The following is a description of a gene set: Human Gene Set: HP_ABNORMALITY_OF_CENTRAL_NERVOUS_SYSTEM_ELECTROPHYSIOLOGY species: Homo sapiens Abnormality of central nervous system electrophysiology, and this is the list of marker genes: SCARB2, GJC2, ZNHIT3, PPFIBP1, IER3IP1, LAMC3, B3GALNT2, MT-TL1, WWOX, GRIN2D, NPRL3, HIC1, JRK, MAP2K2, PRNP, COL13A1, MADD, MTMR2, UGDH, TLR3, CLCN2, CHRNA4, C1QBP, SHQ1 (SHQ1, H/ACA ribonucleoprotein assembly factor), HNRNPU, ALDH7A1, AHDC1, NECAP1, FGFRL1, GLS, DOCK7, UCHL1, PURA, MAPK10, PACS2, ST3GAL5 (ST3 beta-galactoside alpha-2,3-sialyltransferase 5), MOGS, CPLX1, ATXN1, LRPPRC, ATP6V1A, PI4KA, FOXG1, PIGG, VAMP1, ZNF526, PDE2A, UPB1, KCNC1, CDKL5, TUBGCP2, CLCN4, PROM1, RUSC2, APC2, SCN1B, SLC5A7 (NCBI Gene Id 60482), GOSR2 (golgi SNAP receptor complex member 2), SLC25A10, DALRD3, HECW2, KCTD7, XPC, HMGCL, ADGRV1, NEU1, TPRKB (TP53RK binding protein), CUL3, KARS1, SLC35A2, ATXN10, IQSEC2, PHACTR1, MYO9A, KCNQ2 (potassium voltage-gated channel subfamily Q member 2), RERE, CUL4B, RELN, NTRK2, GABRG2, YRDC, MFSD8, SPTBN1, POMT1, MTHFR, ARSA, HRAS (NCBI Gene Id 338029), PRKCZ, PEX10, DOLK, DEPDC5, GABBR2, SATB1, AHSG, UBA5, ASPA, ACOX1, PEX6, CEP85L, NDRG1, ST3GAL3 (NCBI Gene Id 6487), SNIP1, FKRP, ARFGEF1, PIK3CA, MT-TH, TBC1D2B, NDUFAF8, TRPM3, ABCB7, TRIM8, FXN, EPG5, YWHAG (NCBI Gene Id 96443), D2HGDH, SMS, CTBP1, CLCN7, BRAF, POMGNT1, NALCN, ATP6V0A1, PRDM16, ATP1A3, ALS2 (NCBI Gene Id 65058), PCDH12, RTN2, ABCC8, DNM1, DIAPH3, ADGRG1, UBAP1, CNTNAP2, AARS1, NDP, NMNAT1, PDHA1, NEDD4L, GAD1, SLC6A1, GLUD1, NTNG2, ARHGEF2, CSTB, SLC1A4, SCN1A, PPT1 (palmitoyl-protein thioesterase 1), FOXP1, FLII, PTS, POLG, DOCK6, ADK, PRPS1, MT-ND5, NUS1, CLN8, HCN1, COQ4, GRIA3 (NCBI Gene Id 2892), ERCC4, CACNA2D1, CDK19, COMT, COG3, PEX3, PEX16, AIMP2, NUP107, AFG2A, NDUFA9, CABP4 (NCBI Gene Id 57010), HIKESHI, SLC18A3, PIGW, MARCHF6, SRPX2, CHI3L1 (chitinase 3 like 1), IARS2, TNFSF11, ABCD1, EMC1, TUBB2A, SH3TC2, SLC2A1, NLGN4X, MCOLN1, WDR62, ATP6V1B2, COX6B1, PLPBP, PRRT2, ALDH4A1, SYNJ1, NPRL2 (NPR2 like, GATOR1 complex subunit), NDUFS2, UBTF, SPG7, LARS2, SLC12A6, CNTN2, PRKAG2, DENND5A, DHPS, TBC1D24, CPT1C, ERCC1, RPL10, GABRB3, PLCH1, EP300, LONP1, STXBP1, MTHFS, AMT, PRODH, SETBP1, FDXR, DHDDS, AARS2, OCRL, SLC39A8, TRAPPC12, KPTN, TBK1, NSRP1, CLTCL1, PEX11B, RAB3GAP1, ERCC2, BRAT1, MFF, MFN2, ALDH5A1, ATAD1, NDUFS4, SPG11, MT-ND4, DPM2, GABRD, PCDH19, RNF13, LSS, PHGDH, ABCA4, GABRA1, AASS, ABAT, EDNRB, PLCB1, KMT2D, CHD2, MT-ND6, SMC1A, CTNNA2, MED23, CREBBP, TYR, PIGT, PIGO, OTOF (otoferlin), AP3B2, TRIT1 (NCBI Gene Id 54802), PIGV (phosphatidylinositol glycan anchor biosynthesis class V), DNM1L, VCP, DNAJC30, CERS1, CDK5, EOGT, NACC1, SOX10, GABRA5, APOL2, ADRA2B, NOTCH2NLC, TGFB1, LAMA2, SLC32A1, OTUD7A, CAMK2A, KANSL1, GALC, BCS1L, TYROBP, PIGP (NCBI Gene Id 53821), RAB3GAP2, CACNA1H, GLYCTK, SLC9A6 (NCBI Gene Id 53362), GABRA2, AFG3L2, SEMA6B, POMT2, IREB2, ERCC3, CNPY3, TICAM1, NOTCH3, OSTM1, PEX13, SLC44A1, CPA6, MED13L, GRIN2A, PHF6, NSF, TRAPPC11, NRAS, ANKRD17, CLTC, XPA, LMNB1, PSAP, PIDD1, CWC27, MT-TW, MYH3, ATN1, ITPR1, SCN8A, MT-ND1, MT-TS2, NTNG1, PDPN, SUOX, SLC13A5, NUP188, OCA2, GNAO1, YWHAE, MT-CO2, SLC6A19, CACNA1B, FGF13, PLP1, PNKP (polynucleotide kinase 3'-phosphatase), KCNA2, SYNGAP1, SCN2A, KCNT2, SUCLA2, SCN3A, SPTAN1, CELF2, PSAT1, GFM2, MYD88, VAMP2, CLTRN, PEX12, STRADA, PI4K2A, SYT1, TIMM8A, PLAA, MT-CYB, ROGDI, NHLRC1, PIGL, OPA1, FKTN, ARFGEF2, SLC33A1, SETD1B (NCBI Gene Id 23067), GUF1, FLCN, POGZ, FARS2, DNM2, SNAP25, MGAT2, PPP3CA, SLC25A22, MMP23B, ALG11, MDH1, NAXD, DAG1, NSD2, ACTL6B, AAAS, NGLY1, FRRS1L, ZNF148, ESAM, PEX19, LARGE1, NEFL, CYP27A1, CACNA1A, SACS, DPM1, ARHGAP31, DCX, ALG3, FGF12, CHAT, DMXL2, MT-CO1, SLC25A1, ALG13, TTPA, PCK1, VARS2, CASK, MAP1B, SNX10, PRICKLE1, TBC1D20, WASHC5, SPEN, KCNT1, CHRNA2, ERCC8, VARS1, CACNA1E, PTRH2, KRAS, DEAF1, GRM7, P4HTM, UFC1, MT-ND2, MYT1L (NCBI Gene Id 4662), GRIA1, SQSTM1, KCNA1, SLC12A5, ALG1, ARX, ARHGEF9, MPDU1, PEX2, NF1, TBL1XR1, CUX2, GNB5, EXOC8, NLGN3, ERMARD, EEF1A2, DAOA, ANKRD11, CAPRIN1, GABRB1, SAMD12, DDB2, DDC, GOLGA2, MORC2, CHMP2B, PRUNE1, TIMM50, FBXO28, DPAGT1, HYCC1, CAMSAP1, ELOVL4 (ELOVL fatty acid elongase 4), CRPPA, ANTXR1, CYFIP2, RDH11, SLC1A2, NLRP3, TET3, AP3D1, RIPOR2, NECTIN1, ABCA5, SLC1A3, CBS, HCFC1, GRN, AGRN, AP1S2 (adaptor related protein complex 1 subunit sigma 2), CNGB3, DLL4, CHRNB2, NOTCH1, STARD7, PLA2G6, HTR2A, ASL, MED17 (NCBI Gene Id 9440), GCSH, PARS2, HID1 (NCBI Gene Id 80791), RAI1, MECP2, PEX14, SYN2, MT-ATP6, YME1L1, NUP133, GABRB2, CASZ1, RTN4R, RAB18, ZEB2, EFHC1, PRPH2, PEX1, KCNMA1, SIK1, LIPT2, RMRP, UNC80, ALG2, SNRPN, RBPJ, NARS2, CILK1, EIF2S3, TP53RK, GRIN1, HSPG2, MT-TF, TRAF3, EBP, AKT3, MECR, CLCN6, AIMP1, CTNND2, PIGY, PGAP2, WDR73, STX1B, DRD3, SLC25A46, HIBCH, SYT2 (synaptotagmin 2), SV2A, SCAPER, KCNAB2, UBE3A, ARG1, CARS2 (NCBI Gene Id 79587), NBEA, WDR45, TBCK, PSEN1, DPYD, UBE4B, BCKDK, KDM6A, CCDC47, CRH, ATP7A, PTPN23, TCIRG1, GRIA4, UNC93B1, SCN9A, TRAK1, GRIN2B, WDR4, KCNB1, GMPPB, NEXMIF, MAPT, KCNH1, EPM2A, CCDC88A, NEUROD2, ERCC6, TMEM106B, ASNS, TREM2, YEATS2, MT-TQ, AP2M1, GPAA1, ATP10A, SNF8, OSGEP, ITGB6 (integrin subunit beta 6), RTTN, PIGA, GNB2, MTOR, PEX26, FZR1 (fizzy and cell division cycle 20 related 1), CACNA1G, KCNC2, ADARB1, ERCC5, SKI, CACNB4, CNKSR2, SLC38A3, GNB1, SPTBN4, COX4I1, COX16, GON7, LETM1, STUB1, LUZP1, MAF, PIGS, ATP1A2, PNPO, APOL4 (NCBI Gene Id 80832), PEX5, MT-CO3 (mitochondrially encoded cytochrome c oxidase III), ALG14, ARV1, KCNQ3, PGAP3, LGI1, PAFAH1B1, MT-ND4L, KCNJ11, LAGE3, PIGQ, SZT2, MAP2K1, TFE3, KPNA3